The following is a description of a gene set: Phospholipid metabolism studied in species Homo sapiens Human Gene Set: REACTOME_PHOSPHOLIPID_METABOLISM, and this is the list of marker genes: FIG4, PLEKHA1, PLA1A (phospholipase A1 member A), AWAT2, PLBD1, MTM1 (myotubularin 1), TPTE, PCYT2 (phosphate cytidylyltransferase 2, ethanolamine), GPAM, MTMR1, ETNK1, PLAAT1, CDS2, INPP5K, ENPP6, PIK3R4, ABHD4, PLA2G1B, CHAT, AGK, CEPT1, PLA2R1, PLAAT4, LPIN2, GDPD5, CSNK2B, HADHB, SBF2, PIKFYVE, PLA2G10, ETNPPL, PITPNB, PCTP, OSBPL5, BCHE, PI4K2A, ARF3, DGAT2, PTEN, PGS1, OCRL, PLAAT2, PIK3R2, MTMR4, PITPNM2, PLEKHA3, ARF1, PLEKHA8, PLA2G4F, PLEKHA4, PTDSS2, PIP5K1A, PLEKHA2, PI4KB, LPCAT2, PIP5K1C, CPNE7, RAB5A, ALPI, INPP5J, CSNK2A1, PNPLA8, PLA2G2D, PIP4K2B, CDIPT, PLD2, CRLS1, MTMR3, PIK3CG, INPP5F, AGPAT2, DDHD1, TAFAZZIN, CPNE6, LIPH, OSBPL8, CHPT1, PIK3CA, AGPAT4, PITPNM3, SYNJ2 (synaptojanin 2), ACHE, PLA2G6 (NCBI Gene Id 8398), PLA2G4C, SLC44A2, RAB14, SYNJ1, INPP4B, STARD10, GPD1, RAB4A, PLA2G4D, BMX, STARD7, TNFAIP8L1, CHKB, PI4KA, MTMR7, PLA2G2E, CSNK2A2, PLA2G2F, MTMR14, RUFY1, PIK3C2G, INPP4A, PIK3R6, DDHD2, SELENOI, GPCPD1, PTPN13, DGAT2L6, AGPAT5, GPD1L, LPCAT4, PIK3CB, PGP, GPAT3, PLA2G4A, VAC14, PLA2G15 (phospholipase A2 group XV), GDE1, LCLAT1, LPCAT3, PIP4K2A, PCYT1B, SLC44A4, PLA2G12A, PLA2G5, MBOAT1, PNPLA6, PI4K2B, PLD1, PIK3C2A, PLD3, PLAAT5, GDPD3, PNPLA3, PNPLA7, MBOAT2, CHKA, PIK3R1, PTPMT1, PLA2G4E, CPNE3, GPAT2, PLA2G4B, MBOAT7, MTMR2, MTMR9, SLC44A5, MGLL, INPP5D, PIP4P1, AGPAT1, TNFAIP8L2, SBF1, HADHA, PHOSPHO1, PLA2G2A, ABHD3, TNFAIP8L3, PIK3C2B, PCYT1A, ETNK2, PITPNM1, PISD, PIP4K2C (NCBI Gene Id 79837), INPP5E, MTMR8, PLA2G3, GNPAT, PIK3R5, PLD6, MTMR10, PIK3C3, MTMR12, PLD4, MFSD2A, PIP5K1B, PEMT, LPIN1, SLC44A1, PLB1, GDPD1, MIGA2, INPPL1, PLAAT3, SLC44A3, LPIN3, MTMR6, PTDSS1, DGAT1, SACM1L, PIK3CD, TNFAIP8, OSBPL10, MIGA1 (NCBI Gene Id 374986), CDS1, AGPAT3, LPCAT1, PLEKHA6, GPAT4, PNPLA2, PIK3R3, LPGAT1, TMEM86B, TPTE2, CPNE1, ACP6, GPD2, LIPI, PLEKHA5